The following is a description of a gene set: Human Gene Set: GSE3720_VD1_VS_VD2_GAMMADELTA_TCELL_WITH_PMA_STIM_DN species: Homo sapiens from publication Kress E, Hedges JF, Jutila MA (PMID 16423401) The two major human gd T cell subsets, Vd1 and Vd2, display differences in tissue tropism and agonist responses, but we have little insight into global differences that may exist at the gene expression level. This is due to the small numbers of these cells that can be obtained from healthy donors, which limit comprehensive, comparative gene expression analyses. We established a culture method that expands Vd1 and Vd2 cells from the same PBL preparation to levels sufficient for sorting and microarray analysis. Although the subsets were expanded identically (anti-TCR mAb, plus IL-15), 392 and genes were identified, which were differentially expressed in the two subsets, from two donors, respectively. Approximately genes changed in both subsets following PMA/ionomycin treatment; about 50% of these genes were subset-specific. Both subsets responded to a crude LPS preparation, but only 6% of the responsive genes were the same. The differentially expressed genes were consistent with Vd2 cells being more inflammatory and Vd1 cells having more of a regulatory phenotype. Both subsets expressed transcripts encoding an array of innate and NK cell receptors, supporting the relationship of gd T cells to the innate immune system. Our results show that circulating Vd1 and Vd2 subsets in humans have considerable, inherent differences in gene expression following treatment with non-TCR agonists, supporting unique functional roles for these cells in vivo. Genes down-regulated in gamma delta T cells stimulated by phorbol myristate acetate and ionomycin: Vd1 versus Vd2., and this is the list of marker genes: LAPTM4B, GAREM1, PCDHA12, BCR, RBM11, CBR1, GM2A, TRIP4, CACFD1, MAGED2, MFGE8, EBF3, IFNGR2, WFDC5, ZNF219, DNAJB5, PLIN3, NAGK, MNT, KCTD14, ODF2L, MROH1, LRRC20, WBP1, TMEM50A, DNAJC4, BOLA1, ZMYM2, FBXW10, MMS19, RAD51B, TEC, TBC1D19, ARHGAP18, FBXW4, FAM193B, GALK2, VPS28, PI4K2A, ZUP1, POP4, COQ8B, MAGEE1, GAD1, TSPAN32, SLC4A11 (NCBI Gene Id 9574), ZNF217, BOD1, IFFO2, ARMC10, SERTAD4BP, APH1B, DGUOK, PPP2R5B, RHOG, ADRB2, CCDC61, FUCA1, SERF1A, ID2, TECPR1, SURF1, FBXO6, CCNL2, TMED3, HSPB7, SLC17A7, ALDH1B1 (aldehyde dehydrogenase 1 family member B1, NCBI Gene Id 219), ECH1, TEP1, RNF11, GABBR1 (NCBI Gene Id 2550), KDM3B, EHMT2, B4GALT3, SPG11, TMBIM1, NPRL2, RTF2, KHK, GABARAPL1, MIER1, DLGAP4, PSTPIP1, C3orf70, CNPY3, STX16, SNORD104, CYTH2, PWWP3B, C18orf21, IDH3B, HAGHL, PJA1, DDB2, ALDH3A2, UCKL1, ACOT13, LDLRAD3, ETV5, TNC, EXT2, PLEKHB2, HMGCL, ATF5, TTC39C, USP20, EZH1, TRIM24, FOXJ2, SH3BP5, TEFM, CCNI, TBC1D16, COX14, USP3, ACAA1, APOC4, CREB5, EIF3H, MTMR1, TOR2A, RFXANK, SLC15A1, MTHFR, RPL4, PDLIM7, ITPR2, KLC2, HMBOX1, IKZF4, PPP2R3A, PXK, DNAJB14, TAFAZZIN, RNF25, FAH, SOX15, FMNL3, TRPM5, BAZ2A, PRICKLE3, ENTPD2 (NCBI Gene Id 954), PPOX, SH3D19, CHD2, AFAP1L1, SMOX, FHIP2A (FHF complex subunit HOOK interacting protein 2A), TMEM175, THY1, USF2, TMED4, OAZ2, ADCY10, ABHD14B, PRMT2, GNAL, AARS2, SPIN1, ATG12, RAP2A, PDE6D, HSD17B10, ANXA13, KMT5C (NCBI Gene Id 84787), ADAMDEC1, MNAT1, XPR1, SRI, MARVELD1, TM2D2, TMEM87B, MSH5 (NCBI Gene Id 4439), PHF20, ZNF7, LRRC34, DIP2C, RNF130, LIN7B, MAPK11, VPS26A, SIRT7, NMNAT1, HDAC5 (histone deacetylase 5), SLC25A38, STOX1, RBMS2, ATP6V0D1, KATNB1, BLOC1S5, FAM219B, HECTD4, TSC22D3 (NCBI Gene Id 64477), MAPK3, ARSA, SYT16, SLC12A7 (NCBI Gene Id 26129), NUDT14, KCNK13